The following is a description of a gene set: Human Gene Set: WP_DDX1_AS_A_REGULATORY_COMPONENT_OF_THE_DROSHA_MICROPROCESSOR DDX1 as a regulatory component of the Drosha microprocessor species: Homo sapiens, and this is the list of marker genes: MRE11, ATM, DDX1, NBN, DROSHA (drosha ribonuclease III), RAD50, DGCR8